The following is a description of a gene set: Mouse Gene Set: MIR_7242_3P species: Mus musculus from publication Chen Y, Wang X (PMID 31504780) Genes predicted to be targets of miRBase v22 microRNA mmu_miR_7242_3p in miRDB v6.0 with MirTarget v4 prediction scores > 80 (high confidence targets)., and this is the list of marker genes: Msmo1, Slc9a6 (solute carrier family 9 (sodium/hydrogen exchanger), member 6), Cep57, Trim33, Veph1, Ndst1, H2bc23, Ugt2b1, Gdpd5, Kctd7, Paip2, Rai14, Gjc3, Sntg1, Atp1a2, Otop3, Pgrmc2, Zcchc24, Ankdd1b, Pacs2, Proz, Papolg, Tspan5, Edem3, Hephl1, Rapgef6, Rhbdf1, Rcor2, Slc1a4, Marchf8, Cnot6l, Dkc1, Prkg1, Fgf9, Cxcr3, Sh3pxd2a (NCBI Gene Id 69633), Nrf1 (nuclear respiratory factor 1), Zfp41, Sh3bgrl2 (SH3 domain binding glutamic acid-rich protein like 2), Shank2 (NCBI Gene Id 210274), Dmtf1, Srsf6, Ccdc85a, Ezh2, Ppp1r16b, Mex3c, Grin3a, Nr6a1, Wfikkn2, Socs6, Patl1, Zfp418, Diaph1, Skint3, Erbb4, Spn, Grk6 (NCBI Gene Id 26385), Tmem104, Slc39a13, Lin28b, Cdk6, Pacsin1, Stox2 (NCBI Gene Id 71069), Cacnb2, Kng1, Tbl1xr1, Nav1, Pcdhb3, Zmym3, Rgs17, Ttbk2, Usp54, Parp16, Tfdp1, Gm5544, Adora2a, Zfp704, Prx, Trim3, Cxxc5, E2f3, Clcc1 (chloride channel CLIC-like 1), Hbs1l, Zc3h11a, Gpd2, Akap13, Crkl (v-crk avian sarcoma virus CT10 oncogene homolog-like), Chmp1b, H2bc24, Rasa3, Kcnq2, Nectin1, Celf6, Mapk3 (NCBI Gene Id 26417), Pakap, Myo5a, Suds3, Galnt7, Dnajb12, Olfm1, Ifit2, Cluh, Itk, Slc25a31, Anks1, Fbxo33, Qser1, Mfap4, Carm1, Rab7, Mtfr1l, Ralgapa1, Rnf169, Gnpnat1, Zfp341, Zmiz1, Rarg, Rgs12, Arih2, Myt1l, Rgs8, Sos1, Agrn, Nrip3, Dip2b, Slc4a8, Spg7, Cdc14b, Mical3, Tmem183a, Hycc2, Vapb, Rabgap1, Setbp1, Kif17, Snx24, Astn1, Ntng1, Eeig1, Hmgxb4, Nat8l, Slc4a4, Hnrnpdl, Ash1l, Pfn1 (profilin 1), Rbm5, Tmprss11f, Tmem255a, Ldlrap1, Styk1, Csnk1d (casein kinase 1, delta), 4933402D24Rik, Nr2c2, Eci1, Enoph1, Cadps2, Lamp1